Given this list of marker genes Sp5, Marchf4, Rora, Zbtb9, Usp22, Siglecl2, Csgalnact1, Chd3, Tmem50b, Mycl, Smad6, Lratd2, Lingo3, Tmpo, Cyp11a1, Nhsl3, Maz (NCBI Gene Id 17188), Aebp2, Atp1b1, Kmt2a, Dennd1b, Ywhaz, Camkk2, Psip1, Adcyap1r1, Gjc3, Ei24, Wdr5b, Tnfaip1, Cabp5, Pgrmc2, Ebf3, Metap1, Cdh11, Cacul1, Zfp930, St3gal1, Fam168a (NCBI Gene Id 69223), Mob3b, Daam1, Necap1, Cdh12, Kcnj2, Rgcc, Slc30a7, Tm4sf4, Osgepl1, Leng8, Mlec, Arhgap44, Ppp2r1a, Tmem164, Pcyt1b, Eif4ebp1, Psg23, Rad1, Plekha6, Rab18, Ppargc1a (peroxisome proliferative activated receptor, gamma, coactivator 1 alpha), Atp6v1g3, Lrrc3, Prcp, Ncoa4, Elovl2, Ciao1, Ankrd17, Pgm2l1, Fam241a, Bpnt2, Lzts3, Vezt, Appbp2 (amyloid beta precursor protein binding protein 2), Slc45a4, 1110059G10Rik, Uba6, Hnrnpul1, Selenoi, Alg11, Jph4, Usp14, Styx (NCBI Gene Id 80592), Pabir2, Tomm40l, Ino80d, Ywhag, Ctnnd2, Tmed5, Nup210, Syn3, Lrrc27, Des, Idh3a, Tent4a, Trpc5, Dock5, Faf1, Itgal, Gm13889, Zfp704, Fhl3, Cdk5 (NCBI Gene Id 12568), Zdhhc3, Gimap8, Rit2, Pmf1, Zeb2, Chd9, Kdm7a, Npm1, Hao1, Ube2r2, Gtf3c4, Megf8, Rimoc1, Hdgf, Dgkk, Mapk10, Rabgap1, Ncam1, Plekhh1, Tcf7, Sly, Ttpal, Npas3, Kmt2e, Gm20736, Tacr3, Trpm8, Chtf8, Sh3kbp1, Strada, Parvb, Steap2, Rcan1, Kifbp, Fgd3, Midn, Semp2l2a, Sox11, Usp48, Vsig10l, Relch, Krtap26-1, Sema3d, Sirpa, Ddn, Btaf1, Gm12185, Aamp, Cdh3, Rcc2 (regulator of chromosome condensation 2), Nfia, Palm, Cwc15, Uchl5, Hectd3, Dlc1, Best1, Fam53c, Bicd1, Tfcp2l1, Scube2, Shisa7, Ccdc177, Rps6ka2, Tfrc, Maml2, Pcdhb14, Fam163b, Kirrel3, Mboat7, Ergic1, Gas7, Stxbp6, Limch1, Rad51ap1, Nipsnap1, Rdx, Stxbp5, Ms4a13, Kirrel1, Ablim3, Phc1, Urah, Snx12, Rab5b, Slc9a6, Hecw2, Megf10, Igsf9b, Zfp229, Trabd2b, Hook3, Tbp, Dcx, Pctp, Efr3b, Mapk8 (NCBI Gene Id 26419), Ube4a, Fn1, Ybx2, Wdr26, Fbxl7, Snx11, Thoc2, Adgrl3, Vps25, Srpk2, Osbp, Rtl5, Hdlbp, Ndst2, Pear1, Rfx2, Klf1, Thy1, Ddx39a, Slc25a21, Dnajc6, Prkab2, Lamc1, Hcn3, Zmym2, Tigd3, Sox30, C1qtnf6, Satb1, Uroc1, here is a description of the gene set: Genes predicted to be targets of miRBase v22 microRNA mmu_miR_1953 in miRDB v6.0 with MirTarget v4 prediction scores > 80 (high confidence targets). Mouse Gene Set: MIR_1953 species: Mus musculus from publication Chen Y, Wang X (PMID 31504780)